The following is a description of a gene set: Genes predicted to be targets of miRBase v22 microRNA mmu_miR_491_5p in miRDB v6.0 with MirTarget v4 prediction scores > 80 (high confidence targets). species: Mus musculus from publication Chen Y, Wang X (PMID 31504780) Mouse Gene Set: MIR_491_5P, and this is the list of marker genes: Stk32b, Dsc1, Elavl4, Khdrbs1, Hcfc1r1, Cd37, Golph3l, Nos1, Ier5, Nckap5l, Ogfod1, Strip2, Aar2, Endov, Bbx, Guca2b, Gpr179 (NCBI Gene Id 544812), Rtp3, Mex3a, Trarg1, Wdr12, Slc7a1, Pde1c, Dok4, Hnf4a (hepatic nuclear factor 4, alpha), Elavl3, Tmem35a, Ddah1 (NCBI Gene Id 99881), Dmc1, Ube2o, Atad1, Sorcs2, Plxnd1 (NCBI Gene Id 67784), Plp2, Dnaja2, Irf3, Pecam1, Carhsp1, 3110082J24Rik, Crybg3, Cts8, Phf13, Syndig1l, Ttyh3, Fhl3, Pdgfra, Vwa1, Unc5b, Scamp4, Phf12, Luzp1, Ski, Csrp1, Amd2, Sytl4, Ino80d, Ankrd10, Wars1, Msn, D430041D05Rik, Tnfsf4, Pip4p1, Ppp1r9b, Igf2, Stc1, Zfp644, Trim43b, Erf, Dspp, Myt1l, Tmem104, Lrrc15, Celsr3